Given this list of marker genes Ighg2c, Iglc1, Igkc, Ighg1, Igkv15-103, Ighg2b, Iglc3, Iglc4, Igll1, Iglc2, Ighg3, here is a description of the gene set: A protein complex composed of two identical immunoglobulin heavy chains of an IgG isotype and two identical immunoglobulin light chains, held together by disulfide bonds. An IgG immunoglobulin complex may be embedded in the plasma membrane or present in the extracellular space, in mucosal areas or other tissues, or circulating in the blood or lymph. species: Mus musculus Mouse Gene Set: GOCC_IGG_IMMUNOGLOBULIN_COMPLEX